Given this list of marker genes NINL, GNA14, LUC7L2, SLC43A1, LMNA, EPOR, NXPE2, NECAB3, AK5, WWC2, PTPN3, NECAP2, FASTKD2, PIN4, SETD6, PPP3CB, SNX5, WDR35, ALG11, WDFY3, EPB41L5, PLEK2, BEND3, MYO1D, SMIM13, RNF20, DHRS4, ANK1, TUT7, MRPL54, ASB17, SLC12A2, GAB1, ATP8A1, FECH, HIF3A, RETREG3, LPIN1, STX11, TPST1, PITPNC1, SCML2, TAL1, ALAD, PLA2G4C, PVT1, RIF1, CKS1B, LDB1, ABCA3, LIAS, PIP4K2C, CKS2, ADGRE5 (NCBI Gene Id 976), LMCD1, SIK3, C1orf50, GARRE1, BLM, CA1, CISD1, PRDX2, ZNF266, APLP2, SLC35E2B, PABPC4, CELF1, TSPO2, SDHA, TSC1, CENPV, MGLL, FAAP24, MTHFD1, PORCN, AGPAT4, E2F2, DZIP1, SLC25A30, MFHAS1, NOL9, ZFPM1, POLR1D, RECQL4, ATP1B2, SPTA1, ADD2, METAP2, RNF19A, SLC7A4, SNCA, LTBP1, ACP1, PRCP, PLXNA2, SPIRE1, ARHGAP23, SOD1 (NCBI Gene Id 6647), ZBTB43, TNIK, LEPROT, APLN, HIVEP1, DPY19L1 (NCBI Gene Id 23333), ADD1, LRRC8C, SLC26A1, NMNAT3, CDIN1, MBD3L1, CECR2, NEK1, XPR1, SLC22A23, MUSTN1, EXOC6, RYK, PHACTR4, HEBP1, STRADB, SH3TC2, JMY, CPOX, BOD1L1, HSPH1, NKX1-2, DTL (NCBI Gene Id 51514), BCL7A, CHEK2, LSM14A, PEX5, FADS2, TUSC2, PXMP2, MEX3D, HK1, UBLCP1, CTH, C1QTNF12, RAB22A, NAGS, BLTP3A, UBXN1, KLF3, EPDR1, HPN, NKAP, NSD3, DDIAS, ACSS1, MINPP1 (multiple inositol-polyphosphate phosphatase 1), GRB10, PGAP4, CITED4, FBXO30, SELENOT (NCBI Gene Id 51714), TUFT1, SFXN2, ABCB10 (ATP binding cassette subfamily B member 10), TNFAIP2, GLRX2, KLHL12, AGAP1, SLC12A4, GPAM, STX17, CCNB1IP1, EHD3, ZMAT3, GPR155, ENO3, MYLK3, ARHGAP12, TGFBR3, KEL, IPMK, SEPTIN8 (septin 8), GLRX5, GDPD1 (NCBI Gene Id 359824), GP5, TFDP2, VSTM5, ATP5IF1, CRACD, PLK1, ATL1, XPNPEP1, NQO1, FAM234B, BDH1, USP25, NARF, SAMD14, CYTH3, CA2, ZMYM5, DAAM1, DCAF12L1, ATP13A3, FAM210B, here is a description of the gene set: species: Homo sapiens Removal of the transcription factor SAP1a member of the Ternary Complex Factor (TCF) group of transcription factors which in conjunction with Serum Response Factor (SRF) has been shown to have a profound effect on positive selection in the thymus. When another TCF Elk1 is knocked out in mice there is no effect on positive selection unless it is on a Sap1a KO background where the phenotype is very severe. We have stimulated isolated double positive T cells (DPs) with anti-CD3 to mimic positive selection and compared basal and stimulated transcription across the four genotypes to discover the downstream targets of Sap1a involved in positive selection. from publication Costello P, Nicolas R, Willoughby J, Wasylyk B, Nordheim A, Treisman R (PMID 20554967) Human Gene Set: GSE21546_SAP1A_KO_VS_SAP1A_KO_AND_ELK1_KO_ANTI_CD3_STIM_DP_THYMOCYTES_UP Genes up-regulated in double positive thymocytes stimulated by anti-CD3: ELK4 knockout versus ELK1 and ELK4 knockout.